Given this list of marker genes Lum, C1qb, Col6a4, Dcn, Marco, Colec11, C1ql2, Col9a2, C1qa, Col5a3, Colec10, Col15a1, Sftpd, Fcnb, Eda (ectodysplasin-A), Col24a1, Col19a1 (NCBI Gene Id 12823), Col17a1, Col18a1, Col4a4, C1qtnf3, Adipoq, Col9a1, Col4a5, Colq, Col20a1, Col13a1, C1qtnf7, Col8a2, C1qtnf2, Otol1, C1ql3, Scara3, C1qtnf5, Cthrc1, Mbl1, Col5a2, Col8a1, Col1a2, C1ql1, Emid1, Mbl2, Col4a3, Col23a1, Gldn, Col28a1, Col6a1, Emilin1, C1qtnf6, Sftpa1, C1qtnf1, Msr1, Ccbe1, C1ql4, Col26a1, Col7a1, Col4a1, Col10a1, Emilin2, Col27a1, C1qc, Fcna (ficolin A), Col2a1, Col4a6, C1qtnf9, Col11a2, Col6a5, Col5a1, Col25a1, Col6a3, Col12a1, Col16a1, Col3a1, Col11a1, Col6a6, Wdr33, Colec12, Col4a2, Col1a1, Lox, Col9a3 (NCBI Gene Id 99252), Col14a1, Col6a2, here is a description of the gene set: A protein complex consisting of three collagen chains assembled into a left-handed triple helix. These trimers typically assemble into higher order structures. Mouse Gene Set: GOCC_COLLAGEN_TRIMER species: Mus musculus